Given this list of marker genes GPIHBP1, LPL, APOC2, APOA1, APOA2, APOA4, APOA5, APOC3, APOB, APOE, here is a description of the gene set: Human Gene Set: REACTOME_CHYLOMICRON_REMODELING Chylomicron remodeling studied in species Homo sapiens